Given this list of marker genes Ccdc66, Mid1, Ccdc13, Spag9, Zmynd10, Gnai1, Katnip, Tex9, Ccdc61, Wdr62, Bbs4, Cep162, Pax2, Rassf7, Lhcgr, Rpp25, Gpr174, Lrrc49, Tek, Flot1, Cntrl, C2cd3, Fam184a, Pja2 (NCBI Gene Id 224938), Hook3, Krt18 (NCBI Gene Id 16668), Dcdc2a, Rab11a, Cyth4, Odf2l, Knstrn, Ccdc112, Tmem63a, Taf1d, Pard6a, Rab11fip5, Tacc3, Cd2ap, Ptpn23, Rab8a, Ccdc15, Mib1, Rrm1, Tpgs2, Bbs5, 4933427D14Rik, Bbs1, Aldob, Nek1, Harbi1, Chd3, Zbed6, Plk1, Exoc7, Cstpp1, Cep290, Dbh, Ift43, Wdr13, Stap1, Ccno, Cep20, Cep63, Patj, Pcm1, Nlrc3, Ska1, Lats2, Pdzd2 (NCBI Gene Id 75144), Il4ra, Bbs2, Lrif1, Podxl, Keap1, G6pdx, Agtpbp1, Ccdc57, Cep68, Frmd8, Pibf1, Cep72, G6pd2, Flii, Ssx2ip, Trappc14, Tap1, Cenpu (centromere protein U), Trat1, Ccdc113, Cep57, Rbm39, Ttc8, Ocrl (NCBI Gene Id 320634, OCRL, inositol polyphosphate-5-phosphatase), Mdm1, Kif5b, Klhl12, Mdm2, Nek6, Sdccag8, Cd86, Cyld, Asap1, Ddhd2, Dysf, Pxk, Rab11fip3, Nr0b1, Itgb1bp1, Wdr90, C2cd5, Rabl6, Naa40, Ubn1, Bbs7, Cep131, Fnip2, Ythdf2, Ofd1, Nudt21, Ak5, Gnai3, Mpp1, Klhl4, Prkcq, Cfap53, Dzip1, Bbs9, Ccdc14, Pcnt, Tbc1d31, Upf3b, Braf, Spag5, Cspp1, Myof, Pacsin2, Ptpn20, Ccdc18, Cdc42bpg, Pik3r5, here is a description of the gene set: species: Mus musculus A small (70-100 nm) cytoplasmic granule that contains a number of centrosomal proteins; centriolar satellites traffic toward microtubule minus ends and are enriched near the centrosome. Mouse Gene Set: GOCC_CENTRIOLAR_SATELLITE